The following is a description of a gene set: Mouse Gene Set: GOBP_REGULATION_OF_BRANCHING_INVOLVED_IN_SALIVARY_GLAND_MORPHOGENESIS Any process that modulates the rate, frequency, or extent of branching morphogenesis in the salivary gland epithelium. studied in species Mus musculus, and this is the list of marker genes: Pdgfa, Hgf, Fgf10, Ntn4, Cdh1, Fgf7, Tnf, Fgfr1, Btbd7 (BTB domain containing 7), Snai2, Met